Given this list of marker genes ALOX15, ALOX5, PTGS2, ALOX12, here is a description of the gene set: Reactome Pathway: Biosynthesis of DPAn-3 SPMs part of: Biosynthesis of DPA-derived SPMs The polyunsaturated fatty acid (PUFA) ω-3 cis-7,10,13,16,19-docosapentaenoic acid (DPAn-3) is an intermediate in the biosynthesis of docosahexaenoic acid (DHA) from eicosapentaenoic acid (EPA) and is also a precursor for the production of novel bioactive mediators. The proposed biosynthesis of specialised proresolving mediators (SPMs) derived from DPAn-3 is described here. The products of the ω-3 isomer were characterised based on DHA (docosahexaenoic acid) derived resolvins, protectins and maresins. The same biosynthetic route as DHA-derived SPMs is probably how DPAn-3 products are also formed. studied in species Homo sapiens